The following is a description of a gene set: Urea cycle and metabolism of amino groups Human Gene Set: WP_UREA_CYCLE_AND_METABOLISM_OF_AMINO_GROUPS species: Homo sapiens, and this is the list of marker genes: OAT, ACY1, PYCR3, PYCR1, GATM, ARG2, GLUD1, SRM, SMS, CKB, GAMT, ASL, ASS1, ARG1, CPS1, NAGS, ALDH18A1, CKM, ODC1, OTC, SARDH